The following is a description of a gene set: Aplasia/Hypoplasia of the phalanges of the hand Small or missing phalangeal bones of the fingers of the hand. species: Homo sapiens Human Gene Set: HP_APLASIA_HYPOPLASIA_OF_THE_PHALANGES_OF_THE_HAND, and this is the list of marker genes: NPR2, SF3B4, ALG6 (NCBI Gene Id 94752), DDR2, ERF, EIF2AK3, SMC3, EXTL3, POC1A, PCNT, KCNH1, IDH1, GJA1, ATP6V1B2, MBD5, SETBP1, TRPV4 (NCBI Gene Id 8098), HOXD13, PIGF, CHST3, HNRNPR, NOG, BRD4, ARID1A, PRKG2, PIGO, COL10A1, HDAC4, PIGB, DLL4, GJA5, ADAMTS2, VAC14, GNAS, PIK3CD, EDA, ARHGAP31, PORCN, NEPRO, DPYS, PIGV, XYLT1, GPC4, FZD2, PGAP3, SRCAP, ARSL, FLNB, TRIP11, KCNJ2, MIA3, DYNC2LI1, GPC3, MIR17HG, KMT2D, BHLHA9, CCDC22, CEP152, EVC, GGCX, PIGL, JAG1, HOXA13, NOTCH1, GMNN, MTOR, DYM, PTDSS1, TAF6, ACTL6B, PIGW, CHST11, ACVR1, FGFR2, MEG3, ERI1, COMP, PIGY, RBM8A, PCYT1A, IHH, KDM5C, IFT43, PIGN, ACP5, TBX5 (T-box transcription factor 5), RIPK4, PIGS, MCTP2, BRF1, TRIO, MGP, WNT5A, PTH1R, DNA2, PTCH1, BMP2, RAI1 (NCBI Gene Id 6600), GJA8, CRKL, IL11RA, NIPBL, WDR19, EIF4A3, WNT7A, DOCK6, PTHLH, WDR35, RAB23, SMARCE1, BGN, SLC26A2, PRKAR1A, MAP3K7, ABCC9, NOTCH2, POR, FLNA, RECQL4, ROR2, STAMBP, LBR, RPS6KA3, GNB2, CDH11, ZMPSTE24, FBN1, IFT52, FN1, EDA2R (NCBI Gene Id 60401), CNOT1, NXN, IFT57, BMPR1B, GLI1, KMT2A, SMARCB1, MEGF8, ARID1B, ROBO1, SMARCA2, COL11A2, GLI3, PUM1, DVL3, FIG4, KAT6B, KDM6A, TRPS1, PUF60, CWC27, IFT122, IFT140, CANT1, NSDHL, BCR, MYCN, SLC25A24, ZBTB20, FTSJ1, VPS35L (VPS35 endosomal protein sorting factor like), LAMA5, EOGT, PDE3A, KIF15, RAD21 (NCBI Gene Id 5885), RBBP8, EVC2, GPX4, LMNA, HDAC8, ASCC3 (activating signal cointegrator 1 complex subunit 3), LIFR, RBPJ, DLK1, FANCI (NCBI Gene Id 751608), PRKACB, TFAP2B, PRKACA, INTU, SOX11, LONP1, SHH, SH3PXD2B, TWIST1, KCNN3, XRCC2, SMC1A, TBX3, FANCD2, FGFR1, BMP4, NIN, CBFB, RAB3GAP2 (NCBI Gene Id 26114), PRMT7, MECOM, PHF6 (NCBI Gene Id 84438), CRIPT, TP63, MAPK1, DVL1, COG4, INPPL1, KCNJ8, IGF2, SOX9, TBC1D24, PDGFRB, FGFR3, COL2A1, GNPNAT1, TGFBR2, RUNX2, LMBR1, RAB33B, DNMT3A, PIEZO2, PGAP2, SALL4, SLC39A13, CHUK, NHS, HHAT, NFIX, POLA1, ANAPC1, KNSTRN, RTL1, PDE4D, FRAS1, CLCN7, GDF5